The following is a description of a gene set: CD4 T follicular helper (Tfh) cells provide the required signals to B cells for germinal center reactions that are necessary for longlived antibody responses. However, it remains unclear whether there are CD4+ memory T cells committed to the Tfh lineage after antigen clearance. Using adoptive transfer of antigen-specific memory CD4+ subpopulations (based on CXCR5 and Ly6c expression)in the LCMV infection model, we found that there are distinct memory CD4+ T cell populations with commitment to the Tfh and Th1 lineages. Our conclusions are based on gene expression profiles, epigenetic studies and phenotypic and functional analysis. The gene expression profiles of virus-specific CD4 T cell subets at effector and memory stages is presented here. Human Gene Set: GSE43863_NAIVE_VS_MEMORY_TH1_CD4_TCELL_D150_LCMV_DN studied in species Homo sapiens Genes down-regulated in CD4 SMARTA T cells: naïve versus Th1 memory. from publication Hale JS, Youngblood B, Latner DR, Mohammed AU, Ye L, Akondy RS, Wu T, Iyer SS, Ahmed R (PMID 23583644), and this is the list of marker genes: ROPN1L, CFAP53, KDM4A, KANK2, CPSF2, SPRED1, PAEP, SIN3A, NKAIN1, FAM161A, PSG3, ANGPT4, RPS2, SPINT3, PRSS37, CLHC1, MIR646HG, SEPTIN7P2, PIGR, ARRB2, PIN1P1, CLPTM1, EEF1G, NRG1, RTN4R, NSUN7, NSMAF, GNG13, FAXC, ENSG00000291006, GZMA, LCMT1-AS2, PAH, CCDC24 (NCBI Gene Id 149473), HLA-DPB2, ZNF669, NAGS, PRRG3, HMGB3P22, FSTL5, GPR88, KIF20B, DMAC2L (distal membrane arm assembly component 2 like), TTTY2, FLJ12825, LRRC2, MROH2A, STEEP1, SFRP4, PCDHGA10, NUP210P1, VPS11 (VPS11 core subunit of CORVET and HOPS complexes), VSNL1, CLEC14A, VCP, PARP3, RAB2A, PRIM2, SLCO1A2, MPG, CACNB2 (NCBI Gene Id 783), DECR2, ATP8B4, ADAM21, GPX3, SNAI2, CACNA2D1, RFWD3, SMCP, ADAMTS20, WEE2-AS1, TBR1, EYA2, OMD, SGIP1, TIMD4, DLG1-AS1, ZNF813, BPY2, POLR2J2, ARRDC3-AS1, LINC00630, PPM1H, SNRPC, HERC2P3, LINC02901, C9, MTFR2, ARL6IP6, TBC1D32, CADM3-AS1 (NCBI Gene Id 100293330), CCL21, FAM169A-AS1, PALS2, PCDHB5, TRAPPC6A, SLC9C2 (NCBI Gene Id 284525), B9D1, ENTPD7, LDHAL6A, CNGA4, MINDY2, CCL18 (C-C motif chemokine ligand 18), TIMM23B, DCLRE1B, UPK1B, SLC17A3, DPPA5P4, SNX24, CHRNB1 (NCBI Gene Id 1140), FAM133A, FANCD2OS, KCNK13, KCTD5 (NCBI Gene Id 91152), NIPSNAP1, MYORG, ADGRE1, EVI2B, KCNK12, LRRC34, CDK5R1, SOX9-AS1, LMBRD2, DEFA4, SH3GL2, NLRP10, PDE6C, IFNA14, POLM, CACUL1, CAMKMT, MAP2K6, SOX13, ZNF143, COX8A, ANKRD33, FSD2, OPALIN, INAVA, FAIM, CHAF1B, OR1G1, ISYNA1, LRRC75A, SENP8, GABRG3, ZNF30, LRRC37A4P, OLAH, PBX3-DT, LINC02800, RPL29, SCARF2, SFXN2, TAF5LP1, RPL10, TRMT2B, GABRQ, TMEM145, RNF180, MYB, ELMOD1, HEATR4, ST6GALNAC4, DSC2, SHISA2, CYP4A11, RAG2, LINC01123, ENSG00000282375, GDF9, GSTZ1, LINC01354, FIGN, VPS13B, EPHA4, CIMIP2B, ARHGEF5, ANGPTL1, LINC01091, ANKRD33B, CEACAM8, ULK4, UGT3A1